Given this list of marker genes ASAH1, PLP1, BRF1 (NCBI Gene Id 90137), TAF1, PRNP, BTD, UBE3B, here is a description of the gene set: studied in species Homo sapiens An abnormal high-pitched noisy sound, occurring during inhalation or exhalation caused by the incomplete obstruction in the throat. Human Gene Set: HP_LARYNGEAL_STRIDOR Laryngeal stridor